Given this list of marker genes CSK, NR1H4, TREM2, MIR27A, MIR185, IL19, ITGB3, LDLR, MIR199A1, CNPY2, ANXA2, MYLIP (myosin regulatory light chain interacting protein), ITGAV, FGF21, MIR27B, ABCC8, KHSRP, MIR148A, LDLRAP1, APOC3, HNRNPK, MIR17, MIR133A1, PCSK9, here is a description of the gene set: studied in species Homo sapiens Human Gene Set: GOBP_REGULATION_OF_LOW_DENSITY_LIPOPROTEIN_PARTICLE_CLEARANCE Any process that modulates the rate, frequency or extent of low-density lipoprotein particle clearance. Low-density lipoprotein particle clearance is the process in which a low-density lipoprotein particle is removed from the blood via receptor-mediated endocytosis and its constituent parts degraded.